Given this list of marker genes USP18, IFIT2, MX1, FGD4, HERC5, HLTF, WDR70, RIOX2, SMARCAL1, OAS2, OAS3, C1QB, SLC8A1-AS1, PARP14, SAC3D1, PRSS16, PLAC8, GCH1, PIN4, C15orf61, DDX60, DTX3L, MVB12A, PML (PML nuclear body scaffold), IFI44L, CTBP2, MX2, IL15, FMNL2, CX3CR1, DHX58, PSME2, RSAD2, AKR7A2, KIAA1958, BTK, SECTM1, TMEM165, JUP, ST3GAL5, CMPK2, CALML4, KMO, IFIH1, IFFO1, PCCA (NCBI Gene Id 5095), TNS3, CHFR, IFI27, BATF2, TBC1D8, FNIP2, CTSL, IFIT1, IFI44, C11orf24, EFNA4, ISG15, LY6E, OASL, C1QA, TRIM69, IRF7, B3GALT6, SELPLG, ADAR, SMCO4, HERC6, CXCL11, OR52K3P, PARP12, SASH1, LAP3, SAMD4A, IRF8, LINC00487, GTF2H1, SRBD1, BPHL, SPATS2L, DECR1, VSIG10L, MTHFD1, SLC31A2, ANKRD22, ZNF479, IMMT, CXCL10, TXLNA, DDX19A, RIGI, STAT1, CDKN1C, BST2, ZDHHC16, FAM13A, PPP1R11 (protein phosphatase 1 regulatory inhibitor subunit 11), VPS45, SAMHD1, TCF7L2, FBXO6, IFIT3, GNS, BLVRA, GBA1LP, IFITM1, FANCL, CSK, TLL1, ADPRH, TRIM14, ADAP2, SCARB2, IFI6, XAF1, TMEM168, EIF2AK2, MS4A4A, TOR1B, SIDT2, FERRY3, DDX60L, FCGR1BP, NYNRIN, HLA-DPA1, KLHDC7B, SERPINA7, IFITM3, PARP10, LAMP3, OAS1, VAV2, CNDP2, FGD2, IGFBP7, LCP2, PMM2, RPE, PHF11, GPBAR1, AATBC, TAP1, TNFSF13B, SIGLEC1, RTP4, EOLA1-DT, LARP1, MOV10, IL27RA, ADISSP, CNP, ABCC10, PIK3AP1, NID1, GBP1, SLC25A43, AIM2, SHFL, VIPAS39, NREP, TRIM5, PLXNC1, SNAPC3, DNAJC13, TMT1A, NADK, SAMD9L, MYOF, SERPING1, ARHGAP31, MEGF9, RTCB, UBE2L6, TBCE, ATP10D, SCO2, EAF2, RGL1, TLR5, RAD50, STAT2, MARCKS, VRK2 (VRK serine/threonine kinase 2), SANBR, IFITM2, PHF19, PARP9, PLSCR1, MARCHF1, EPSTI1, CYSLTR1, C3AR1, FCGR3B, C2, TRIM22, C1orf53, LILRB1, APOBEC3A, C1orf162, here is a description of the gene set: from publication Querec TD, Akondy RS, Lee EK, Cao W, Nakaya HI, Teuwen D, Pirani A, Gernert K, Deng J, Marzolf B, Kennedy K, Wu H, Bennouna S, Oluoch H, Miller J, Vencio RZ, Mulligan M, Aderem A, Ahmed R, Pulendran B (PMID 19029902) The immune responses generated by YF-17D by profiling genes in 25 vaccine recipients were accessed at days 1, 3, 7, and 21 post-vaccination compared to pre-vaccination in PBMCs. The immune responses generated by YF-17D by profiling genes in 25 vaccine recipients were accessed at days 1, 3, 7, and 21 post-vaccination compared to pre-vaccination in PBMCs. Genes down-regulated in comparison of unstimulated peripheral blood mononuclear cells (PBMC) versus PBMC 3 days after stimulation with YF17D vaccine. studied in species Homo sapiens Human Gene Set: GSE13485_CTRL_VS_DAY3_YF17D_VACCINE_PBMC_DN